The following is a description of a gene set: Metaphyseal irregularity species: Homo sapiens Human Gene Set: HP_METAPHYSEAL_IRREGULARITY Irregularity of the normally smooth surface of the metaphyses., and this is the list of marker genes: CFAP410, ARSB (arylsulfatase B), RPL13, ACP5, TONSL, DYM, DNAJC21, SLC34A3, IARS2, CSPP1, CYP2R1, KIAA0586, QRICH1, TRPV4, DDRGK1, NANS, BGN, RMRP, EFL1, GPX4, SRP54, PRKG2, FN1, IDH1, SLC17A5 (NCBI Gene Id 6479), LPIN2, NEK1, PEX5, FGFR3 (NCBI Gene Id 55546), SBDS, MMP13, MATN3, ASCC3, COL2A1, LBR, CLCN5, NKX3-2, CYP27B1, SIK3, EXOC6B, RAB33B, CASR, MMP9, GNPNAT1, PTH1R, VDR, COL10A1, COMP, KIF22, PCYT1A, RSPRY1, PHEX, SLC35D1